The following is a description of a gene set: Mouse Gene Set: GOBP_CYCLIC_GMP_AMP_TRANSMEMBRANE_IMPORT_ACROSS_PLASMA_MEMBRANE The directed movement of cyclic-GMP-AMP from outside of a cell, across the plasma membrane and into the cytosol. species: Mus musculus, and this is the list of marker genes: Shoc2, Lrrc8d, Lrrc8e, Lrrc8c, Slc19a1, Lrrc8b, Slc46a2, Lrrc8a